The following is a description of a gene set: studied in species Homo sapiens Genes predicted to be targets of miRBase v22 microRNA hsa-miR-219b-5p in miRDB v6.0 with MirTarget v4 prediction scores > 80 (high confidence targets). from publication Chen Y, Wang X (PMID 31504780) Human Gene Set: MIR219B_5P, and this is the list of marker genes: R3HDM1, PTN, CCDC47, TM9SF1, VEZF1, NUP205, ZSCAN16, MTCP1, FAM9B, GMPPB, PLPPR5, APRG1, NOL8, CDH11, UNC5C, CCDC141, TARDBP, RGS12, TP53TG3B, TMEM65, CNOT2, TP53TG3D, B3GAT2, CST9L, TP53TG3, MID1, MIER3, SREK1, SS18, SKAP2, KNSTRN, GGA3, DICER1, ZNF189, LOXL2, MAST4, RELCH (NCBI Gene Id 57614), ZBED4, LSM8 (NCBI Gene Id 51691), PDLIM1, FAM20A, RCN1, PLEKHA8, FANCD2, CCDC180, AK4, ANKHD1-EIF4EBP3, RNF19B, RBM26 (NCBI Gene Id 64062), RBM27, NAMPT